Given this list of marker genes Ggps1, Fdps, Ptar1, Pdss1, Fnta, Pggt1b, Pdss2, Cox10, Fntb, Nus1, Fdft1 (farnesyl diphosphate farnesyl transferase 1), Rabggtb, Dhdds, Rabggta, Coq2, Ubiad1 (NCBI Gene Id 71707), here is a description of the gene set: Catalysis of the transfer of a prenyl group from one compound (donor) to another (acceptor). Mouse Gene Set: GOMF_PRENYLTRANSFERASE_ACTIVITY studied in species Mus musculus